Given this list of marker genes Adipoq, Pgk1, Eif6, Ubr4, Mir199a-2, Egr1, Nr1h2, Agt, Nfe2l1, Ppargc1a, Pibf1, Ces1c, Elovl5, Pdk1, Lpgat1 (lysophosphatidylglycerol acyltransferase 1), Ncor1, Tysnd1, Ces1d, Acsl4, Kcnma1, Bmp2, Insig1, Mtln, Pparg, Fabp3, Prkag2, Fmo2, Clcn2, Prox1 (NCBI Gene Id 320240), Dkk3, Irs1, Sirt1, Bmp5, Il1b, Apoc2l, Eif2ak3, Cmtm2a, Insig2, Rdh10, Ins1, Mapk9, Creb1, Prmt3, Pdk3, Pdk2, Ceacam1, Rdh1, Ces1e, Ptgs2, Dkkl1, Nucb2, Erlin2, Prkg1, Dcaf5, Hnf4a, Irs2, H6pd, Bckdk, Pdk4, Adck2, Slc45a3, Sox9, Ghsr, Rdh16, Apoc2, Anxa1, Pla2g4a, Mlycd, Fabp1, Bglap2, Sirt5, Apoc1, Wdtc1, Rest (NCBI Gene Id 72127), Ncor2, Apoa5, Gprc6a, Ces1g, Pank2, Abcd2, Ces1f, Ppard, Avpr1a, Dgkq, Mir214, Gk, Erfe, Trib3, Cnr1, Acadvl, Etfbkmt, Trex1, Acacb, Malrd1, Ppara, Apoc3, Dgat1, Fmo1, Akt2, Fmo4, Mid1ip1, Erlin1, Plin5 (NCBI Gene Id 66968), Fgf15, Twist1, Gdf15, Ces1a, Acsl5, Dab2, Snca, Fabp5, Rgn, Obp2a, Sirt2, Rdh9, Cpt1a, Klhl25, Nr1d1, Srebf1, Abcb11, Ggcx, Cyp7a1, Rdh16f2, Mfsd2a, Mtor (mechanistic target of rapamycin kinase), Slc22a13, Lonp2, Pla2g3, Cav1, Appl2, Avp, Star, Akr1c18, Rdh19, Apoa4, Wnt4 (NCBI Gene Id 22417), Stard4, Dbi, Bmp6, Fgfr4, Ceacam2, Ankrd26, Cd74, Ces1h, Brca1, Kat2b, Pptc7, Bglap, Ins2, Ces1b, Abcd1, Acadl, Nr1h3, Mlxipl, C1qtnf2 (NCBI Gene Id 69183), Scap, Dgat2, Tpk1, Akt1, Gip, Sirt4, here is a description of the gene set: species: Mus musculus Any process that modulates the chemical reactions and pathways involving any of a class of organic compounds that contain the carbonyl group, CO, and in which the carbonyl group is bonded only to carbon atoms. The general formula for a ketone is RCOR, where R and R are alkyl or aryl groups. Mouse Gene Set: GOBP_REGULATION_OF_KETONE_METABOLIC_PROCESS